Given this list of marker genes ATF4, SUMO1, ANK3, RGS4, NOS3, KCNE1, CAV3, PTK2B (NCBI Gene Id 5748), CAB39, HCRT, KEL, CASQ2, HTR2A, KCNAB1, NEDD4, KCNE5, MIR212, MIR29B1, KCNRG, NOS1, ACTN2, KCNE2, MIR26A1 (NCBI Gene Id 407015), MIR30D, WWP2, MIR103A1, BIN1 (bridging integrator 1), GRP, KCNQ1, NEDD4L, OXSR1, STK39, KCNE3, CAV1, KCNH2, here is a description of the gene set: Any process that stops, prevents, or reduces the frequency, rate or extent of the directed movement of potassium ions (K+) into, out of or within a cell, or between cells, by means of some agent such as a transporter or pore. Human Gene Set: GOBP_NEGATIVE_REGULATION_OF_POTASSIUM_ION_TRANSPORT studied in species Homo sapiens